The following is a description of a gene set: Hippo-YAP signaling species: Homo sapiens Human Gene Set: WP_HIPPOYAP_SIGNALING, and this is the list of marker genes: LATS2, MAP4K4, RASSF1, CXCL10, STK3, MAP4K3, STK38L, TEAD4, LATS1, MST1, YAP1, WWTR1 (NCBI Gene Id 25937), TEAD1, SAV1, TEAD2, NDRG1, TNIK, TEAD3, NF2, MAP4K2, MAP4K1, MINK1